Given this list of marker genes CYP2U1, CLPTM1, GLIPR1L2, TMEM47, ZNF407, GSTM2, RNF38, GPR89A, FGF14, TRIM33, ZNF85, NAALAD2 (NCBI Gene Id 10003), ATP6V1C1, AFF3, RAB6B, RNGTT, KIF3B, KIAA1549L, TOP2A, USP3, ATPAF1, SFXN5, CHRM1, TARDBP, UBL3, HMMR, SLC10A7, GNAT1, XKR6, GPR89B, PGK1, LGR6, DHX40, GCG, CDH2, COL19A1, ST3GAL1, CHD9, FUT4, PAK3, EFCAB5, BTRC, DSTYK, CREB3L1, FEZ2, GTF2I, ZC3H12B, HSPB7, ARF4, ALDH3A1, MEIS2, ST7, CHRD, ZNF248, SH3BGRL2, GRSF1, NUDT13, ARX, EVPLL, UGT2B4, VASH2, KDM7A, EPYC, RNF180, UHRF1, FXYD6, P2RX1, C1QTNF3, here is a description of the gene set: Genes predicted to be targets of miRBase v22 microRNA hsa-miR-8077 in miRDB v6.0 with MirTarget v4 prediction scores > 80 (high confidence targets). species: Homo sapiens Human Gene Set: MIR8077 from publication Chen Y, Wang X (PMID 31504780)